Given this list of marker genes ACADVL, ACADM, HADHB, ACSM6, HADH, ACSM3, HADHA, ACADS, ECHS1, MECR (NCBI Gene Id 554211), ACADL, here is a description of the gene set: part of: Mitochondrial Fatty Acid Beta-Oxidation species: Homo sapiens Once fatty acids have been imported into the mitochondrial matrix by the carnitine acyltransferases, the beta-oxidation spiral begins. Each turn of this spiral concludes with the repetitive removal of two carbon units from the fatty acyl chain. beta-oxidation of saturated fatty acids (fatty acids with even numbered carbon chains and no double bonds) involves four different enzymatic steps: oxidation, hydration, a second oxidation, and a concluding thiolysis step, resulting in the two-carbon acetyl-CoA and a newly CoA primed acyl-CoA for the next turn of the spiral. Reactome Pathway: mitochondrial fatty acid beta-oxidation of saturated fatty acids